Given this list of marker genes NNMT, GNMT, AHCY, SCLY, CTH, MAT1A (NCBI Gene Id 4143), CBS, HNMT, here is a description of the gene set: Human Gene Set: REACTOME_METABOLISM_OF_INGESTED_SEMET_SEC_MESEC_INTO_H2SE species: Homo sapiens Metabolism of ingested SeMet, Sec, MeSec into H2Se